Given this list of marker genes Cd244a, Ifitm2 (interferon induced transmembrane protein 2), Tgfbi, Sult1a1, Casp6, Cdk2ap2, Eif4ebp1, Wfdc17, Ddost, Gatm, Nme1, Ndufs4, Serpina3g, Ldha, Pou2f2, Serinc3, Tspo, Prelid1, here is a description of the gene set: species: Mus musculus Mouse Gene Set: CUI_CDC1_LIF_RESPONSE_UP from publication Cui A, Huang T, Li S, Ma A, Pérez JL, Sander C, Keskin DB, Wu CJ, Fraenkel E, Hacohen N (PMID 38057668) Cytokines mediate cell-cell communication in the immune system and represent important therapeutic targets. A myriad of studies have highlighted their central role in immune function, yet we lack a global view of the cellular responses of each immune cell type to each cytokine. To address this gap, the authors created the Immune Dictionary, a compendium of single-cell transcriptomic profiles of more than 17 immune cell types in response to each of 86 cytokines (>1,400 cytokine-cell type combinations) in mouse lymph nodes in vivo. A cytokine-centric view of the dictionary revealed that most cytokines induce highly cell-type-specific responses. For example, the inflammatory cytokine interleukin-1β induces distinct gene programmes in almost every cell type. A cell-type-centric view of the dictionary identified more than 66 cytokine-driven cellular polarization states across immune cell types, including previously uncharacterized states such as an interleukin-18-induced polyfunctional natural killer cell state. Genes positively differentially expressed in cell type: cDC1 (conventional dendritic cell type 1) upon treatment with cytokine: LIF in mouse lymph nodes in vivo.